Given this list of marker genes TES, BRCA1, PLIN2, ETS2, UCP2, TFF3, NT5E, GIPC2, LY6D, EHHADH, MT2A, PEX11A, LCN2, SLC24A3, PLAT, GATM, PLTP, CBFA2T3, CTSE, VNN3P, BSG, QPCT, NUP205, CD63, COL4A1, TGM2, LEPR, CD36, IGFBP1, KIFAP3, LPL, DAB1, IGFBP2, RAD51B, CIDEA, RAB30, FABP4, SPON2, CHKB (NCBI Gene Id 1120), HOXC6, NIBAN1, ALDH3A2, SLC16A1, COL4A2, CD24, APCS, MFGE8, TM4SF4, SPRR1A, CDKN1A, PMM1, CIDEC, KRT23, PDK4, MLYCD (malonyl-CoA decarboxylase), ABHD2, VNN1, MYO5C, PLA2G7, S100A9, here is a description of the gene set: Genes up-regulated in hepatocellular carcinoma (HCC) induced by ciprofibrate. from publication Lee JS, Chu IS, Mikaelyan A, Calvisi DF, Heo J, Reddy JK, Thorgeirsson SS (PMID 15565109) Genetically modified mice have been extensively used for analyzing the molecular events that occur during tumor development. In many, if not all, cases, however, it is uncertain to what extent the mouse models reproduce features observed in the corresponding human conditions. This is due largely to lack of precise methods for direct and comprehensive comparison at the molecular level of the mouse and human tumors. Here we use global gene expression patterns of 68 hepatocellular carcinomas (HCCs) from seven different mouse models and 91 human HCCs from predefined subclasses to obtain direct comparison of the molecular features of mouse and human HCCs. Gene expression patterns in HCCs from Myc, E2f1 and Myc E2f1 transgenic mice were most similar to those of the better survival group of human HCCs, whereas the expression patterns in HCCs from Myc Tgfa transgenic mice and in diethylnitrosamine-induced mouse HCCs were most similar to those of the poorer survival group of human HCCs. Gene expression patterns in HCCs from Acox1(-/-) mice and in ciprofibrate-induced HCCs were least similar to those observed in human HCCs. We conclude that our approach can effectively identify appropriate mouse models to study human cancers. studied in species Homo sapiens Human Gene Set: LEE_LIVER_CANCER_CIPROFIBRATE_UP